The following is a description of a gene set: studied in species Homo sapiens from publication Amit I, Garber M, Chevrier N, Leite AP, Donner Y, Eisenhaure T, Guttman M, Grenier JK, Li W, Zuk O, Schubert LA, Birditt B, Shay T, Goren A, Zhang X, Smith Z, Deering R, McDonald RC, Cabili M, Bernstein BE, Rinn JL, Meissner A, Root DE, Hacohen N, Regev A (PMID 19729616) Genes down-regulated in comparison of dendritic cells (DC) stimulated with Gardiquimod (TLR7 agonist) at 4 h versus those stimulated with Gardiquimod (TLR7 agonist) at 24 h. mouse primary BMDCs were stimulated with tlr ligands and gene expression changes were profiled on Affymetrix arrays Human Gene Set: GSE17721_4_VS_24H_GARDIQUIMOD_BMDC_DN, and this is the list of marker genes: RILPL2, MYO7A, KLHL7, VPS9D1 (VPS9 domain containing 1), ZYG11B, FOXO3, DNAJC18, SDF2, UBAC1, SLC25A20, FCHO1, PSMB5, C9orf78, PARP3, LRPAP1, COMT, SPOP, SLC15A3, LARS1, LPIN2, SRM, FAM53A, B3GNT2, APOBEC1, RBMS2, SLC35A1, DHX32, TSPO, ST13, DHX16, VPS26B, AKIP1, TXN, LGALS4, ARFGEF1, MRPS7, SUMF1, LDAH, CNPY2 (NCBI Gene Id 10330), STAT6, TM2D3, DPY30, C15orf39, PARP16, TMEM33, TEN1, SERF2, PSMA6, NXT1, USP20, N4BP2L1, MORN4, ENTREP3, TARS1, SGK1, MTRES1, RARS1, DGUOK, NFX1, CYB5R1, TULP3 (NCBI Gene Id 7289), ATP13A2, NDUFAF4, SLC25A51, GPCPD1, SECISBP2L, MTA3, FANCF, GRK2, PINK1 (NCBI Gene Id 65018), NSD1, TOR2A, NLRX1, SRSF10, PARP1, PTPN6, HSP90AA1, FAHD1, SLC6A8, ZFAND2A, C1R, CD2BP2, EOLA1, SMARCA2, POT1, PPBP, CYB5R3, NIF3L1, PLA2G6, SLC39A6, DGKZ, ZNF639, CKS2, PER1, MTURN, PFKFB3, PGM1, CAV1, MRM2, CMTM7, CPT1A, SREK1IP1, NMD3, ARL6IP1, PAFAH2, SEC14L1, CHEK2, ENPP3, NEAT1 (nuclear paraspeckle assembly transcript 1), HCLS1, ALDH7A1, NOMO1, FDXR, ECSIT, MRPL13, CD244, COMMD5, HPF1, PARP2, B3GALNT1, ADH1C, STX17, IVNS1ABP, FRRS1, EIF2AK1, SNX15, RPP25L, BMI1, CUX1, NEK9, YAE1, CLNS1A, TCEAL1, SMARCAL1, DYNLL1, CA13 (NCBI Gene Id 377677), RHOA, KAT2A (lysine acetyltransferase 2A), MAP2K6, MLH3, MXI1, EVI5, PPFIA4, IRX6, INSIG2, LGALS3BP, TDP2, TEFM, LYSMD3, ACSL5, AZIN1 (NCBI Gene Id 51582), MRPS23, RDH13, YPEL3, ARHGAP5, GLG1, LRBA, SUGP2, CDC42SE2, MRPL27 (NCBI Gene Id 64988), CBX4, HTR2B, SUSD6, SNHG8, ZNHIT2, MRPL44, SNX21, ZNF287, LMO4, BIRC6, ERLEC1, NDUFC2, UBE2B, SARS1, ESD, STARD7, PC, SPIDR, ATP6V0E1, TDP1, YPEL5, NCBP1, SKIC8, PRMT5, ENPP2, NAGLU, RHOQ, CRYZL1, TLR8, DGLUCY, HSD11B1 (NCBI Gene Id 3290), CXCR4, GTF2E2, BTK, SLC25A39, ERLIN1 (ER lipid raft associated 1), TNRC6A, RREB1, MOAP1